The following is a description of a gene set: Genes predicted to be targets of miRBase v22 microRNA hsa-miR-663b in miRDB v6.0 with MirTarget v4 prediction scores > 80 (high confidence targets). Human Gene Set: MIR663B species: Homo sapiens from publication Chen Y, Wang X (PMID 31504780), and this is the list of marker genes: TMEM127, TMEM156, RHOJ, PRR23C, DCX, H2AX, DOCK3, C1RL, SH3PXD2A, TTC7B, MAP7D1, GDF10 (growth differentiation factor 10), CYTH4, MYO19, RHOF, C3orf36, ERF, USP47, IQSEC2, SYCE2, ZNF436, SLC66A3, MTCL2, ADGRL2, PHF24, GPRIN2, SMPD1, CIC, PTER, MN1, DHRS2, TTC23, BSPRY, LRTM2, NICN1, STXBP5L, RAVER1, HERC1